Given this list of marker genes PLEKHM1, AXIN1, TCIRG1, CLCN7, TNFRSF11A, here is a description of the gene set: species: Homo sapiens Sandwich appearance of vertebral bodies Human Gene Set: HP_SANDWICH_APPEARANCE_OF_VERTEBRAL_BODIES